Given this list of marker genes Chd1l, Ubb, Ercc2, Usp45, Pold1, Rfc3, Polk, Ccnh, Sumo1, Ddb1, Gtf2h2 (NCBI Gene Id 23894), Ercc3, Rfc1, Pole2, Ino80c, Pold2, Ube2n (ubiquitin-conjugating enzyme E2N), Tfpt, Pcna, Xpa, Rnf111, Nfrkb, Ercc4, Ercc1, Cops6, Pold4, Pole, Cul4b, Ino80b, Gtf2h4, Xpc, Cul4a, Rpa1, Yy1, Rps27a, here is a description of the gene set: part of: Nucleotide Excision Repair Reactome Pathway: Global Genome Nucleotide Excision Repair (GG-NER) species: Mus musculus This event has been computationally inferred from an event that has been demonstrated in another species.<p>The inference is based on the homology mapping from PANTHER. Briefly, reactions for which all involved PhysicalEntities (in input, output and catalyst) have a mapped orthologue/paralogue (for complexes at least 75% of components must have a mapping) are inferred to the other species. electronically inferred by orthology from the curated human pathway